Given this list of marker genes KCNJ2, CLCNKB (chloride voltage-gated channel Kb), KCNJ5, CAV3 (NCBI Gene Id 859), SLC12A3 (solute carrier family 12 member 3), here is a description of the gene set: An anomaly of the U wave of the electrocardiogram (EKG). The U wave is a small (0.5 mm) deflection immediately following the T wave, usually in the same direction as the T wave. It is best seen in leads V2 and V3. species: Homo sapiens Human Gene Set: HP_ABNORMAL_U_WAVE Abnormal U wave